Given this list of marker genes TOM1, CLTB, LMBRD1, GPR107, PICALM, DNAJC6, LRP1, CLTA, SNAP91, CEMIP, LDLR, here is a description of the gene set: studied in species Homo sapiens Human Gene Set: GOMF_CLATHRIN_HEAVY_CHAIN_BINDING Binding to a clathrin heavy chain.